Given this list of marker genes CD2AP, SLC6A11, SFT2D1, EPS8, NUP160 (nucleoporin 160), TRAM1L1, UFSP2, USP24, GRK3, FOXRED2, NCBP2, CLASP2 (NCBI Gene Id 440948), SMIM14, PITPNB, GSPT1, PCDH20, CADM2, SULT1A4, CREBRF, HECTD2, CACNA1B, RAB10, RALGPS2, DAAM1, MID2, NOVA1, COPS3, STAM, LRRN1, ZNF365, AGFG1, DAB2, C21orf91, TNRC6B, GREM2, KCNMB3, SH3PXD2A, SAMD12, TTC31, PREX2, TMPO, KDELR2, CD5L, COBLL1, ABRAXAS2, ZNF519 (zinc finger protein 519), ACVRL1, SSBP2, CARMIL1, ATP2C1, UBE2E1, WDR47, FILIP1L, ALCAM, CD1E, BEND3, UTP15, ARHGDIA, STYX, MINDY4, FAIM, SULT1A3, ZNF611, SHANK2, FNDC1, TMEM265, WAC, PPP2R5C, EGR3, ARHGEF37, C12orf43, VPS13B, HYCC2, GABBR2, PRTG, ZNF385B, TLL2, MRPS21, EGR2, NSA2, LRIG2, MEIS1 (Meis homeobox 1), MPEG1, ZFAND3, FGF9, TPBGL, BCL6, CCDC6, CNPY1, AAK1, CYP7B1, KLHL23, OCLN, ONECUT2, MYBL1, JMJD7-PLA2G4B, NUFIP2 (nuclear FMR1 interacting protein 2), here is a description of the gene set: studied in species Homo sapiens Human Gene Set: MIR1273H_3P Genes predicted to be targets of miRBase v22 microRNA hsa-miR-1273h-3p in miRDB v6.0 with MirTarget v4 prediction scores > 80 (high confidence targets). from publication Chen Y, Wang X (PMID 31504780)